Given this list of marker genes Dvl2, Lrp4, Lck, Gdnf, Vegfa (NCBI Gene Id 22339), Tnfrsf14, Cntn1, Ptpn1, Src, Cav2, Cd80, Ripk2, Epo (NCBI Gene Id 13856), Parp14, Cd3e, Arl2bp, Il4, Mif, Il3, Osm, Il15, Abi2, Nedd9, Il5, Unc119, Il12a, Thbs4, Kit, Isl1, Mlst8, Pecam1, Hsf1, Lilra5, Il13, Crlf1, Lif, Agrn, Ccl5, Tgfa, Wnt3a, Tnfsf18, Itgb1, Icam1, Osbp, Tnfrsf1a, Arhgef2, Iqgap1, Tnf, Adam17, Cd4 (NCBI Gene Id 212762), Abl1, Il24, Ptpn11, Gprc5b, Clcf1, Pdgfra, Il6ra, Cd40, Cass4, Srcin1, Hes1, Il11, Csf2, Grem1, Il6st, Hdac2, Il18, Tnfrsf18, Il2, Hcls1, Ehd4, Efna1, Nrg1, Nox4, Fyn, Itga5, Jak2, Cd44, Fgfr3, Hax1, Adipoq, Il12b, Abi1, Il34, Kitl, Areg, Yes1, Itgb3, Agt, Csf1r, Csf3, Fgf8, Pak2, Lep, Adnp, Ctf1, Angpt4, Clec7a, Fcer1a, Ighm, Sh2d1b1, Fgf7, Mtor, Enpp2, Fbxw7, Igf1, Il23a, Parp9, Tgfb1, Gfra1, Vtn, Il31ra, Tspan9, Tnk2, Nod2, Arrb2, Trem2, Efna5, Fgf10, Dok7, Gata1, Hpx, Acvr1, Pibf1, Ntf3, Prnp, Plpp3, Hes5, Cck, Rasa1, Ins2, Reln, Ptger4, Angpt1, Cd24a, Sh2d1b2, Ifng, Cntf, Tlr4, Abi3, Htr2a, Egf, Musk, Neurl1a (NCBI Gene Id 80633), Lrrk1, Hbegf, Rictor, Vegfb, Erbb4, Il6, Cd74, Dgkq, Il21, Bank1, Cspg4, Ctnnd1, Syk, Bmp6, Ptprz1, here is a description of the gene set: studied in species Mus musculus Mouse Gene Set: GOBP_POSITIVE_REGULATION_OF_PEPTIDYL_TYROSINE_PHOSPHORYLATION Any process that activates or increases the frequency, rate or extent of the phosphorylation of peptidyl-tyrosine.